Given this list of marker genes EXOC6B, CFTR, STX1B, TPRG1L, STX2, RIMS2, GNAO1, UNC13A, EXOC6, VTI1B, STX1A, EXOC1 (exocyst complex component 1), RAB8A, VPS18, RABEPK, STX7 (NCBI Gene Id 8417), USO1, EXOC8, STXBP3, NDRG4, STXBP1, SYTL2, CPLX2, STX17, STX5, EXOC4, CEP83, BVES, STX6, EXOC5, UNC13B, STX19, CLN3, CAV2, SYT1, RIMS3, EXOC3, EXOC7, KCNB1 (NCBI Gene Id 3745), BLOC1S6, STX4, STXBP2, STX12, SNAP25, SNPH, VAMP3, RIMS1, STX10, STX16, STX11, EXOC2, PLEK, STX8, YKT6, UNC13C (NCBI Gene Id 440279), RALB (NCBI Gene Id 5899), STX3, PPFIA3, TSNARE1, VPS11, here is a description of the gene set: The initial attachment of a transport vesicle membrane to the target membrane, mediated by proteins protruding from the membrane of the vesicle and the target membrane. Docking requires only that the two membranes come close enough for these proteins to interact and adhere. Human Gene Set: GOBP_VESICLE_DOCKING studied in species Homo sapiens